The following is a description of a gene set: Human Gene Set: WP_PILOCYTIC_ASTROCYTOMA Pilocytic astrocytoma studied in species Homo sapiens, and this is the list of marker genes: RAF1, SOS1, NF1, GRB2, NRAS, PTPN11, KRAS, HRAS, BRAF